Given this list of marker genes ACVR2A, TULP3, HOXC4, FGF9, HOXA3, FLVCR1, NDST1, DYNC2I1, SMAD2, PAX7, TGFBR1, CDK20, IRX5, HOXD1, PBX1, DLX2, HOXB3, SHOX2, CTNNB1, DMRT2 (doublesex and mab-3 related transcription factor 2), HOXB2, CHST11, EYA1, DLX6, NIPBL, HOXD10, SULF1, SP3, HOXC6, PAX5, HOXD9, SMAD3, GRHL2 (NCBI Gene Id 79977), EDNRA, GLI3, TBX15, GSC, HOXB8, FGFR2, RUNX2, TGFBR2, HYAL1, MDFI, PDGFRA, HOXA4, MYF5, BMP7, LHX1, HOXA1, RDH10, HOXA11, MTHFD1L, HOXC9, ALX1, PRRX1, ALX4, SIX1, HAND2, HOXC5, DEAF1, UCMA, MOSMO, SOX11, HOXB9, DLX3, MTHFD1, HOXB1, TBX1, TFAP2A, HOXB5, FOXC2, SLC2A10, SIX4, FUZ, HOXA9, HOXA2 (NCBI Gene Id 3199, homeobox A2), WNT9A, BMP4, HOXA5, OSR2, RBP4, SLC39A3, SULF2, WDR19, IHH, NODAL, HOXC11, MEGF8, IFT140, BMI1, NOG, PCSK5, SATB2, WNT5A, EXT1, WNT11, DLX1, XYLT1, KIAA1217, SIX2, FGF8, ALX3, HOXA7, SCX, SHH, TWIST1, MED12 (mediator complex subunit 12), DLX5, MMP14, TAPT1, HOXD3, DLX4, HOXB6, HOXD4, COL11A1, NKX3-2, COL1A1, HOXD11, DSCAML1, OSR1, MBTD1, ZEB1, EIF4A3, COL2A1, HOXB7, HSD17B7, MYCN, SLC39A1, MMP16, WNT9B, SLC35D1, MKS1, DLG1, HOXA6, PCGF2, HOXB4, here is a description of the gene set: species: Homo sapiens The process, occurring during the embryonic phase, whose specific outcome is the progression of the skeleton over time, from its formation to the mature structure. Human Gene Set: GOBP_EMBRYONIC_SKELETAL_SYSTEM_DEVELOPMENT